The following is a description of a gene set: Mouse Gene Set: GOBP_PUTRESCINE_BIOSYNTHETIC_PROCESS studied in species Mus musculus The chemical reactions and pathways resulting in the formation of putrescine, 1,4-diaminobutane; putrescine can be synthesized from arginine or ornithine and is the metabolic precursor of spermidine and spermine., and this is the list of marker genes: Paox, Agmat, Odc1, Azin1, Azin2, Ldc1